The following is a description of a gene set: Any process that modulates the frequency, rate or extent of peptidyl-threonine phosphorylation. Peptidyl-threonine phosphorylation is the phosphorylation of peptidyl-threonine to form peptidyl-O-phospho-L-threonine. Human Gene Set: GOBP_REGULATION_OF_PEPTIDYL_THREONINE_PHOSPHORYLATION species: Homo sapiens, and this is the list of marker genes: CHI3L1, MAPK1, STOX1, SPHK1, WNK3 (WNK lysine deficient protein kinase 3), SIRT2, DMTN, IRGM, TRIM6, CADM4, S1PR2, PARD3, CEMIP, EGF, UBE2K